Given this list of marker genes INTS6L, SMG6, TOP2B, HMCES, SYNRG (synergin gamma), WBP1, GPCPD1, COQ10A, CORO7, IFRD1, DYRK1A, ATOSB, ADAM19, CDS2, H2AC25, ETS1, SLC50A1, ANGPTL1, SAMD4B, INPP5F (NCBI Gene Id 22876), IKBKG, STK4, F2R, POLR3GL, BRAP, HECTD1 (NCBI Gene Id 25831), TUBA1A, UBL3, MAFG, SRSF11, SPATA13, ARHGEF18, ABHD17B, ITPKC, FGD2, RBM33, CD2, RAB4B, SMC6, MXD4, ZMYND11, PDCD4, VAT1, ITGB7, TSSK4, HPCAL1, ZC3H11A, RAB11FIP2, CACNA1H, CD79A, STX16, DUSP5, BSDC1, SKI, ACKR2, CYRIB, SESN3, EGR2, LAT, NUMB, MAP1LC3A, NFAT5, SIAH2 (NCBI Gene Id 6478), TMEM121, RPS21, GCOM1, FOXP1, ADAMTS10, DDX50, ARSA, RPL17, MYO9B, LENG8, ELOVL5, TAF13, MYO18A, PRKAB2 (protein kinase AMP-activated non-catalytic subunit beta 2), KLF7, VAMP2, SFT2D1 (SFT2 domain containing 1), MYSM1, ATP10D, CRIP1, LEMD3, NR3C1, ACCS, SFT2D2, HIVEP2, PECAM1, DENND6B, RELCH, PDE2A, CEP57, SLC37A4 (NCBI Gene Id 84965), RANBP9, GOLGA5, USP3, SUB1, TPRG1L, SCAI (NCBI Gene Id 286205), RAB33B, RASA3, HSD17B11, SELENOT, KIF21B, KDM5A, KCTD12, PRKAG1, RMND5A, NOP53, ADRB2, INPP5E, PHF6, ARPC5, P2RY10, CEPT1, CXXC5, SRSF6, ZDHHC18, BTG2 (NCBI Gene Id 7832), NXF1, UBAC2, HERPUD2, AZI2, GLS (glutaminase), MKNK1, INPP5K, AFF3, WIPI2, SLC44A2, BHLHA15, ZFP91, RASGRP2, NFE2L2, NAPSA, GRAMD2B, CC2D1B, GRK6, ATP2A3, ARSK, NUB1, RLIM, C15orf39, SERINC3, MYO1E, EIF1, CYTH1, PIKFYVE, BCL10, KLRC1, DERL1, TXNDC16, UAP1, ZNF692, RIPOR2 (RHO family interacting cell polarization regulator 2), SLK, SARAF, DNAJB2 (DnaJ heat shock protein family (Hsp40) member B2), AVL9, NSD1, RCSD1, UNKL, SLC9A8, COQ8B, RNF167, LNPEP, DOCK11, MDM1, CTBP1, MYL12B, KLHL15, CHD2, GNGT2, TOB1, SETD7, ANKRD13D, MBTD1, ACTRT3, E4F1, CD28, TRPS1, KDM5B, RHOQ (NCBI Gene Id 56679), DYNLT3, TGFBRAP1, FAM193B, DLGAP4, ASPG, PCNX1, ZNF148 (zinc finger protein 148), PDK2, ABCA1, NCOA3 (nuclear receptor coactivator 3), CPSF7, PHF21A, RDH10, ING2, PSEN2, WDR45, GNAQ (G protein subunit alpha q), here is a description of the gene set: studied in species Homo sapiens from publication Doering TA, Crawford A, Angelosanto JM, Paley MA, Ziegler CG, Wherry EJ (PMID 23159438) Human Gene Set: GSE41867_NAIVE_VS_DAY8_LCMV_EFFECTOR_CD8_TCELL_DN Genes down-regulated in CD8 T cells: naïve versus effectors at day 8. During acute viral infections, naïve CD8+ T cells differentiate into effector CD8+ T cells and, after viral control, into memory CD8+ T cells. Memory CD8+ T cells are highly functional, proliferate rapidly upon reinfection and persist long-term without antigen. In contrast, during chronic infections, CD8+ T cells become “exhausted” and have poor effector function, express multiple inhibitory receptors, possess low proliferative capacity, and cannot persist without antigen. To compare the development of functional memory T cells with poorly functional exhausted T cells, we generated longitudinal transcriptional profiles for each.